The following is a description of a gene set: Reactome Pathway: Synthesis of IPs in the ER lumen This event has been computationally inferred from an event that has been demonstrated in another species.<p>The inference is based on the homology mapping from PANTHER. Briefly, reactions for which all involved PhysicalEntities (in input, output and catalyst) have a mapped orthologue/paralogue (for complexes at least 75% of components must have a mapping) are inferred to the other species. species: Mus musculus electronically inferred by orthology from the curated human pathway part of: Inositol phosphate metabolism, and this is the list of marker genes: Minpp1